Given this list of marker genes Bcl2l11, Bad, Ppara, Becn1, Fbln1, here is a description of the gene set: Mouse Gene Set: GOBP_SYMBIONT_MEDIATED_PERTURBATION_OF_HOST_CELLULAR_PROCESS A process in which a symbiont alters or subverts a cellular biological process in its host organism. The host is defined as the larger of the organisms involved in a symbiotic interaction. species: Mus musculus